The following is a description of a gene set: studied in species Mus musculus Binding to a common mediator SMAD signaling protein. Mouse Gene Set: GOMF_CO_SMAD_BINDING, and this is the list of marker genes: Smad2 (NCBI Gene Id 319898), Smad1, Pax6, Gata4, Tgif1, Usp9x, Cited1, Smad6, Smad3, Foxh1, Trim33